The following is a description of a gene set: studied in species Mus musculus Binding to a ceramide, a class of lipids composed of sphingosine linked to a fatty acid. Ceramides are a major component of cell membranes. Mouse Gene Set: GOMF_CERAMIDE_BINDING, and this is the list of marker genes: Gltpd2, Clip3, Pltp, Plekha8, Cert1, Cd300lf, Cln8, Vdac1, Cptp, Vdac2, Mag, Epdr1, Laptm4b, Map1lc3b, Pla2g4a, Psap, Gltp, Rtn4r